Given this list of marker genes APCS, SERPING1, CES1, FTCD, CEBPA, SAA4, HRG, DCXR (dicarbonyl and L-xylulose reductase), SLC22A1, SLC38A3, SERPIND1 (serpin family D member 1), TMEM176A, SDS, HPX, HGFAC, APOC3, ANG, UPB1, ECHS1, CYP1A2, GALK1, HPN, IGFALS, ASGR2, CYP27A1, PROC, RDH16, CYP2C9, MAT1A, C8G, SERPINA4, CYP2D6, ITIH4, HP, ASL, AGXT, CYP2A6, RBP4, CYP2E1, ADI1, AMBP, APOC4, SERPINF2, ADH1C, APOC2, ORM1, MASP2, ITIH1, ORM2, SLC27A5, GSTM1, F2 (coagulation factor II), HSD17B6, HAMP, CIDEB, HPD, LCAT, NNMT, CYP4F12, ASGR1, TST, TMEM176B, CYP2C8, APOC1, here is a description of the gene set: Neighborhood of CEBPA Neighborhood of CEBPA CCAAT/enhancer binding protein (C/EBP), alpha in the GNF2 expression compendium studied in species Homo sapiens Human Gene Set: GNF2_CEBPA